Given this list of marker genes SATB1, AGGF1, SLC50A1, MRC1, CISH, SLC25A39, ATG3, CERS5, ASB4, ZFAND6, BCAP29, IMPDH2, EBP (EBP cholestenol delta-isomerase), CHCHD10, OXCT1, PNPO, ABCB7, SP1, GOT2, ALDH1L1 (NCBI Gene Id 10840), SORD, ALAD, DDHD2, LCMT1, STAP2, CRIP1, RGCC, PLCG2, ABHD4, SDHC, GNPDA1, SEC61B, PTPRS, GNB5, SYNPO, SRSF3, CENPA, MDH1, NXN, GTF2H4, ABHD17A, AIF1, ATP5MC2, NDUFC1, MYO7A, RRM2, RETREG1, SEPTIN4, ITGA6, BACH1, WDR75, CCR2, SLC12A7, DMAC1, CCPG1, IRF2, AP2S1, GNB4 (G protein subunit beta 4), NDUFA5, RELL1, NDUFB6, PLGRKT, SELENBP1, NDUFB10, RPAP3, COPRS, TSPAN4 (NCBI Gene Id 7106), COX6B1, TMEM147, BASP1, FN1, RNF166, NAA10, DEPTOR, METAP1D, LGALS1, STX3, HMBS, SIVA1, MEIS1 (NCBI Gene Id 4211), DOLPP1, MAP3K14, ALDH3B1, ETHE1, UQCR11, GSN, CORO1A, CS, SMC6, TIMM44, PER1, EPHX1, IFI30, RPL37A, RECQL4, LARGE1, CHST12, SNRPB2, CRAT, ADI1, ANKRD46, PPP1R21, RPS14 (NCBI Gene Id 6208), GASK1B, CLNS1A, EFNB1, DHCR7, PLA2G15, MYCBP2, SORL1, RNASE4, AIMP2, GMPR, HSD17B4, NSDHL, MRPL23, FAM120A, ARF3, RAB3IL1, SMYD2, GYG1, NUFIP1 (NCBI Gene Id 26747), PPP1R14B, JARID2, LBR, ITCH, SCARB1, LETM1, LAMTOR4, SRF, CDK4, GPR65, LDHA, POLE3, EEF1D (eukaryotic translation elongation factor 1 delta, NCBI Gene Id 87167), ATRAID, CUTA, CBFA2T3, APRT, PNPLA7, C1QTNF12, PGP, IMPA2, ARRB1, SF1, UBAC1, MRTO4, EEF1G, PELO, FUCA1, DTYMK, SS18, RPS19, BATF3, EEF1B2, RWDD2B, CCT5, PLD4, SPTSSA, TPRA1, GALNT3, TAF10, NDRG4, GMPPA, MYL12B, SPEG, CD99L2, SIDT2, RAB7A, SMC3, POLD2, SH3BP1, ADCY9, NME1, SRPK2, OSGEP (NCBI Gene Id 55644), MCM4, MRPS23, SOX4, RACK1, TIMM8A, ADSS1, SUN1, CGNL1, CUL2, TPD52, STT3B, ATAD3A, ZMPSTE24, PRKD3, MRPS16, PHYH, VSIR, UNC119, MGLL, ARHGAP9, RHOH, MAGEE1, RPA1, MRPL4, here is a description of the gene set: mouse primary BMDCs were stimulated with tlr ligands and gene expression changes were profiled on Affymetrix arrays studied in species Homo sapiens from publication Amit I, Garber M, Chevrier N, Leite AP, Donner Y, Eisenhaure T, Guttman M, Grenier JK, Li W, Zuk O, Schubert LA, Birditt B, Shay T, Goren A, Zhang X, Smith Z, Deering R, McDonald RC, Cabili M, Bernstein BE, Rinn JL, Meissner A, Root DE, Hacohen N, Regev A (PMID 19729616) Human Gene Set: GSE17721_0.5H_VS_12H_CPG_BMDC_UP Genes up-regulated in comparison of dendritic cells (DC) stimulated with CpG DNA (TLR9 agonist) at 0.5 h versus those stimulated with CpG DNA (TLR9 agonist) at 12 h.